Given this list of marker genes Nek9, Chchd1, Nudt6, Cul3, Med7, Slc17a4, Hmgn2, Hnrnpu, Arl5a, Slc38a3, Fxr2, Zc3h6, Gucy1a1, Slc25a20, Ugp2, Brinp3, Ankrd1, Smim17, Krtap1-3, Baz2b, Slc7a13, Arhgef15, Fam228a, Prickle2, Slc7a11, Syndig1, Ndnf, Atf6, Myorg, Map3k9, Nedd8, Cyp7b1, Evi2b, Magee2, Col4a5, Foxp4, Man1a, Rdh13, Elf1, Chrnb4, Il6st, Uts2 (NCBI Gene Id 24111), Plekhb1, Dclre1c, Zfp667, Lrrc55, Dcaf12l2, Erfe, Efna5, Cd160, here is a description of the gene set: Genes predicted to be targets of miRBase v22 microRNA mmu_miR_7084_5p in miRDB v6.0 with MirTarget v4 prediction scores > 80 (high confidence targets). species: Mus musculus from publication Chen Y, Wang X (PMID 31504780) Mouse Gene Set: MIR_7084_5P